Given this list of marker genes TRIB1, ARL5B, EPHA2, FOSL1, TNFAIP3, FOSL2, PLAUR, CCL20, IER3, AREG, TM4SF1, ERRFI1, ZBTB43, ARID5B, TNFRSF12A, ANXA1, CSRNP1, DUSP5, ICAM1, PIM1 (Pim-1 proto-oncogene, serine/threonine kinase), ARL14, DDX21, NCOA7, CXCL2, CXCL1, CDKN1A, MAFF, LIF, GEM, CCN1, MIDN, LUCAT1, ITPKC, NAMPT, ZC3H12A, BIRC3, PIM3, PHLDA1, KDM6B, CCL2, PFKFB3, EDN1, EMP1, HBEGF, PHLDA2, MYADM, MLF1, MYC, FHL2, CXCL8, here is a description of the gene set: from publication Gavish A, Tyler M, Greenwald AC, Hoefflin R, Simkin D, Tschernichovsky R, Galili Darnell N, Somech E, Barbolin C, Antman T, Kovarsky D, Barrett T, Gonzalez Castro LN, Halder D, Chanoch-Myers R, Laffy J, Mints M, Wider A, Tal R, Spitzer A, Hara T, Raitses-Gurevich M, Stossel C, Golan T, Tirosh A, Suvà ML, Puram SV, Tirosh I (PMID 37258682) Genes upregulated in subsets of cells of a given type within various tumors Human Gene Set: GAVISH_3CA_MALIGNANT_METAPROGRAM_22_SECRETED_1 studied in species Homo sapiens In this study, an extensive analysis was conducted to define meta-programs (MPs) capturing intra-tumor heterogeneity across a spectrum of tumor types. The approach utilized non-negative matrix factorization (NMF) to analyze each cell type separately within individual tumor samples. This involved the analysis of malignant cells, macrophages, fibroblasts, endothelial cells, epithelial cells, T-cells, and B-cells. NMF was executed with varying parameter values (K=4, 5, 6, 7, 8, 9), thereby generating 39 programs for each cell type per sample. Each NMF program was summarized by the top genes based on NMF coefficients.\nRobust MPs were then delineated for each cell type using a set of stringent criteria, including recurrence within the same tumor, similarity to programs in other tumors, and non-redundancy within a tumor. Subsequently, these robust NMF programs were clustered (per cell type) based on Jaccard similarity, leading to the identification of MPs associated with each cell type.\nTo enhance the quality of the MPs, a refinement steps were undertaken, involving the removal of MPs suspected of reflecting low-quality data (with an overrepresentation of ribosomal proteins or mitochondrial-encoded genes), single-study inclusion, or similarity to miss-annotated cell types.